The following is a description of a gene set: Human CD14 positive monocytes were purified from healthy volunteers’ blood and cultured in vitro for 4, 12, 24, 72 hours. While culturing, macrophages were activated alternatively with interleukin-4 (IL-4 100 ng/ml) or classically with interferon-gamma (IFNg 100 ng/ml)+tumor necrosis factor (TNF 50 ng/ml) or left without activation. Simultaneously, macrophages were also treated with vehicle (DMSO:ethanol) or 1mM synthetic PPARg agonist, Rosiglitazone. We used Affymetrix microarrays (U133Plus 2.0) to analyze activation and PPARg-induced gene expression changes. Human Gene Set: GSE16385_ROSIGLITAZONE_IFNG_TNF_VS_IL4_STIM_MACROPHAGE_UP studied in species Homo sapiens from publication Szanto A, Balint BL, Nagy ZS, Barta E, Dezso B, Pap A, Szeles L, Poliska S, Oros M, Evans RM, Barak Y, Schwabe J, Nagy L (PMID 21093321) Genes up-regulated in macrophages (12h): IFNG, TNF and rosiglitazone versus IL4., and this is the list of marker genes: NEFL, GABRB1, GRAMD2B, EMC4 (ER membrane protein complex subunit 4, NCBI Gene Id 51234), SRF, ZNF354B, HMGXB3, FRMD4B, DUSP5, CREB3, ZNF655, IRAK3, LUM, TOB2, PPP1R11, ITPRIP, SCGB3A2, IYD, FBXO8, ZFP36L2 (ZFP36 ring finger protein like 2), VGLL2, C2orf88, SEC63, IER2, RPF2, JUNB, KIF13A, PER1, MLLT11, DNAJC16, CD5, C5orf47, PPP1R15A, NOS1, PNPLA1, ADRB2, PIM3, CD274, EGR2, ZDHHC9, TRIB1, CD302, RALYL, NPR2, TRAM2 (translocation associated membrane protein 2), PSME3, E2F4, LRRN1, TP53INP2, ADCY1, AMZ1, TAMALIN, DUSP19, ZFP36L1, AGGF1 (NCBI Gene Id 55109), ADO, DUSP2, HCRTR2, NFKBID, LGR5, PHF6, VAMP3 (NCBI Gene Id 9341), ZNG1B, NUFIP1 (NCBI Gene Id 26747), PRKAB2 (NCBI Gene Id 5565), GPR65, GEM, ARL4C, DDX3X, CDKAL1, PTGER4, CYTIP, TLE1, AAMDC, ARRDC4, LRFN3, EEIG1, TMEM41B, P2RY14 (NCBI Gene Id 9934), TM2D3, GPR171, PILRB, MAFF, MIEF2, RAB19, ERO1B, FASTKD5, RBM18, FGF10, FOSB (NCBI Gene Id 2354), ZMYND8, FAM229B, TRIQK (NCBI Gene Id 647518), GIMAP6, HSD11B1 (hydroxysteroid 11-beta dehydrogenase 1), PNRC1, MYB, IKZF2, ETV3, TRIM15, PPP1R15B, PRKX (protein kinase cAMP-dependent X-linked catalytic subunit), DUSP1, ORAI1, TTC29, NFKBIZ, PREX2, CLDN11, CHD5, NABP1, GALNT13, ITPKB, FILIP1L, DNAJA1, NR4A1, LNX1, ADAMTS9, GPR183, PLEKHH1, TTC19, HSPA5 (heat shock protein family A (Hsp70) member 5), ODAM, FOS, SRFBP1, TSC22D1, PHACTR2, TGIF1, G6PC2, CDK5R1, ADAMTS15, ZNF622, WNT1, AQP8, CHL1, CCDC122, B3GAT2, DNAJB11, MAPK6, CD28, PLEKHG1, TM2D2, CCL4, ARHGAP30, MS4A2, SPRR2A, FKBP1B, DNAJB1, TNFAIP3 (TNF alpha induced protein 3), SRGN, AOC3, KYNU, LRRTM2, SUPT4H1, PLK3 (polo like kinase 3), HSPD1, PTGER2, RILPL2, EGR1, SERPINA7, CTPS1, ARL5B, BCL2L10, XIST, GTPBP8, GDA, RLIM, OPRM1, MATN1, GRIN2B, COQ10B, TFRC, MAP3K8, SUV39H2, SNUPN, STK17B, NDUFA2, SRA1, MIDEAS, SNX18, SPNS2, HMGCLL1, GFI1, MGAT2 (NCBI Gene Id 4247), DGKQ, KBTBD2, ETF1, SBDS (NCBI Gene Id 89877), CTLA4, C6, ZFP36, CD69, CBX8, CLK1, ADIPOR1, BMP7, S100A16, PNLDC1, ASAP2, UBTD1, PLIN2